The following is a description of a gene set: Irregular iliac crest Human Gene Set: HP_IRREGULAR_ILIAC_CREST studied in species Homo sapiens Irregularity of the iliac crest, which is the superior border of the wing of the ilium., and this is the list of marker genes: PAM16 (presequence translocase associated motor 16), IDH1, COL2A1, DYM, LMX1B, GPX4